The following is a description of a gene set: species: Homo sapiens from publication Longo NS, Lugar PL, Yavuz S, Zhang W, Krijger PH, Russ DE, Jima DD, Dave SS, Grammer AC, Lipsky PE (PMID 19023113) Sorted B cells using flow cytometry. CD19 selected B cells were sorted using flow cytometry. Human Gene Set: GSE12366_PLASMA_CELL_VS_NAIVE_BCELL_DN Genes down-regulated in plasma cells versus naive B cells., and this is the list of marker genes: CDK5RAP2 (CDK5 regulatory subunit associated protein 2), MYADM, RCAN3, CELF1, RAB11FIP1, RPS3A, SLC39A10 (solute carrier family 39 member 10), DCLRE1C, OFD1, CBLB, HNRNPR, HNRNPU, POTEKP, RPS16, LFNG, RPL38, RBMS1, MYH9, BTK, ADCK2, KPNA5, STAG2, SETD2, NUB1, H4C3, ARID4B, TSPAN13, PUM3, PTPN6, RPL23A, SNHG6, TASP1, ITSN2, CR2, MBNL3, SPRY1, CEPT1, HNRNPK, WASF2, ZCCHC4, RPL21, ZNF276, FAM43A, ANKRD13A, GNB4, PLEKHG1 (NCBI Gene Id 57480), ACTR3, PRR13, MBP, HK1, ARL11, SUPT16H, UBXN2B, SYNGR2, ZNF573, DHX15, PPP1R18, LINC01138, JAM3, PTPRC, RD3, MKNK2, ZC3H4, RASGRP2, BTF3L4, APH1A, ARRDC2, ARID1A (AT-rich interaction domain 1A), ARHGAP45, ITGB2-AS1, ZC3HAV1, ZNF518B, XYLT1, SLAMF6, PTEN, ZNF395, LARGE2, ADD3, SHISAL2A, HNRNPDL, EEF1A1, CEP68, SCML1, INPP5D, SH3YL1, ZNF512, DNASE1L3, CRKL, CDK3, UTP6 (UTP6 small subunit processome component), ATXN7, CCR6, ATP8B1, INTS15, SRSF1, RPL28, SLA, TBCB, PARP14, UVRAG, ATAD2, HOOK3, KLF2, TRAF3IP3, ZNF652, ZNF655, ZNF736, MED14, TOB2, PARP15, SIK3, CCNG2, ARAP2, CFL1, IFNGR1, ARNT, ERLIN1, NFKB2, TAF4, SORL1, CNOT8, FCER2, MIR600HG, CCDC50, PAWR, BANF1, SNN, ARHGAP15, DENND3, SEMA4F, GMIP, OPN3, FCHO1 (NCBI Gene Id 23149), GM2A, AMMECR1L, IL6, OSBPL11 (NCBI Gene Id 95889), PGS1, ST3GAL1, GARRE1, HNRNPL, AP1G2, MBNL1, PTBP3, RPL7, PRKCE (NCBI Gene Id 5581), CRYBG1, RPL22, ADPRM, SNHG7, THAP12, RAD51AP1, FBXO41, LBR, ATP5MC2, CTDSPL2, FIGNL1, SATB1, GDI2, RASSF5, BDP1, LARS1, EEA1, ZFP36L1, RPS27A, SH2B3, ARHGEF6, FRYL, PHC2, MDN1, USP31, MCM5, HERC6, DDX60, FGR, SERTAD2, CHMP7, DPEP2, CYBB, FXYD5, MYC, RPS6KA3, TLR10, SASH3, DDX21, GABBR1, DR1 (NCBI Gene Id 1810), METTL8, TGOLN2, RPL36, SNX29, TPM3, PIP4K2B, HSF5, LILRB1, RAB14, IRF8, GMFG